Given this list of marker genes H2BC8, H3C6, H2BC12, UBTF, H3C1, H2BC14, GTF2H2, GTF2H5, H2AX, RRN3, H4C5, H3C3, H2BC11, H2BC6, GTF2H3, H4C15, H2BC17, H3C8 (NCBI Gene Id 8355), TAF1D, H3C15, H4C12, POLR2F, H2BC12L, H2AC18, H2BC4, H3C11, H2AC20, H2BC3, H2BC10, POLR1D, MNAT1, H4C2, H2AC8, H2BC13, TAF1A, H4C16, H2BC7 (H2B clustered histone 7), POLR2E, H4C14, POLR1H, H2BC1, H3C10, POLR1A, POLR1E, POLR1C, H2BC21, POLR2K, GTF2H1, H4C1, TBP, H2BC9, H2BC5, POLR1B, H4C4, POLR1F, CCNH, H3C14, H2AC7, H3C7, POLR2H, H3C12, H3-3A, CBX3, H2AB1, H4C9, H2AC4, H4C13, H2AC6 (NCBI Gene Id 8334), H4C11, H4C6, H3C13, ERCC2, TAF1B, H3-3B, CDK7, POLR2L, H2BC15, H4C3, H2AZ2, H4C8, H2BC26, H2AC14, ERCC3, H2AC19, H2AJ, TAF1C, H3C2, GTF2H4, POLR1G, H3C4, here is a description of the gene set: species: Homo sapiens RNA Polymerase I Promoter Escape Human Gene Set: REACTOME_RNA_POLYMERASE_I_PROMOTER_ESCAPE